The following is a description of a gene set: Regulation of cytotoxic T cell responses by Malat1 - miR-15/16 circuit species: Homo sapiens Human Gene Set: WP_REGULATION_OF_CYTOTOXIC_T_CELL_RESPONSES_BY_MALAT1_MIR1516_CIRCUIT, and this is the list of marker genes: CD3E, MALAT1, CD3D, CD80, IL2, CD247, BCL2, CD28, CD3G (CD3 gamma subunit of T-cell receptor complex), CD86, MIR16-1 (microRNA 16-1), MIR16-2, MIR15A, MIR15B, CD27, SPN